The following is a description of a gene set: from publication Coronel L, Riege K, Schwab K, Förste S, Häckes D, Semerau L, Bernhart SH, Siebert R, Hoffmann S, Fischer M (PMID 34197623) Direct target genes of the transcription factor and emerging tumor suppressor RFX7. RFX7 is an emerging tumor suppressor that is activated in response to p53 and stress. Integrative analysis of the RFX7 DNA binding landscape (ChIP-seq) and the RFX7-regulated transcriptome (RNA-seq) in three distinct cell systems revealed direct RFX7 target genes. Direct RFX7 target genes identified in at least two of the three cell lines comprise a set of genes. species: Homo sapiens Human Gene Set: CORONEL_RFX7_DIRECT_TARGETS_UP, and this is the list of marker genes: PIK3IP1, PI4K2A, INTS3, MAF, OTUD5, UBE2H, SLC43A2, TSC22D1, RFX5, PIK3R3, TOB2, ABAT, CDK4, MXD4, TOP2B, DSE, NRSN2-AS1, ATRX, ATOSA, HNRNPUL2, DIP2A, EMC9, CABIN1, TSPYL1 (TSPY like 1), KLF9, REV3L, ARL15, CAT, RAP2A, DOLPP1, RPS6KA5, RMND5A, PDCD4, PTMS, TSPYL2, CIC, CCNG2, CCND1, SESN3, RAB40B, TP53INP1, XRCC1, IP6K2, FAM111A